The following is a description of a gene set: Human Gene Set: GSE19923_E2A_KO_VS_E2A_AND_HEB_KO_DP_THYMOCYTE_DN We wanted to test the role of mammalian E proteins E2A and HEB in the development of T cells. Using a conditional deletion system in which these proteins are deleted at the DP stage of T cell development, we compared DP thymocytes deficient for E2A, HEB or both to wild-type thymocytes Genes down-regulated in double positve thymocyte: TCF3 knockout versus TCF3 and TCF12 knockout. from publication D'Cruz LM, Knell J, Fujimoto JK, Goldrath AW (PMID 20154672) studied in species Homo sapiens, and this is the list of marker genes: UTP3, CRTAP, RASA1, LAP3, SURF2, EIF2B2, FMC1, IDI1, RPL22L1, MYH3, HACD3, EMP1, NCF4, RMDN3, SEMA4D, ANXA5, GK, LGALS3, PLA2G12A, IL13, FHL2, TRAF1, POU2F2 (NCBI Gene Id 5452), ISG15, NUP35, EHF, CR2, GARS1, AIMP2, WNT1, ECE1, NUPR1 (nuclear protein 1, transcriptional regulator), IL10, NUCB2, RCN1, MAPK6, GEM, PSMA6, DAP, TMEM11, TPD52, DDX18, PPDPF, DNAJC1, GGH, IFIT1B, PMS2, NFKBIA, GZMB, CAPN2 (calpain 2), IL4, CD53, CCL7, PTN, LIAS, UBE3A, SERPINB9, CNDP2, SLC1A5, HSD17B12, FDPS, NSUN2, SPP1, NFU1, DNAJB9, CTSB, CASP6, STXBP1, TXNIP, CSTF2T, TM7SF3, GSN, ANXA2, GCH1, AREG, SLFN12L, NID2, PPA2, PLXND1, RUFY1, SRGN, EGR2, ENPP1, NCKAP1, BTG1, AK1, MRPS24, BOP1, ZFYVE16, TBRG1, PLOD3, XCL1 (NCBI Gene Id 92337), CDK8, INSRR, CAPG, CTSC, UGCG, PDZK1IP1, ELL, SUN1, PTPN6, LDLR, ZNF282, MX1, DUSP6, SCEL, MTIF2, FRRS1, ITGAV, TMCO1, SLC12A7, NXF1, ALDOA, SEPTIN9, METAP2, ANXA1, PNPT1, PRKCE, CD82, FBXL5 (NCBI Gene Id 26234), IRF7, JUNB, IL6, SMS, TXNRD2, TANK, DUSP19, ASIP, MRFAP1L1, SLC4A7, FAAP20, KLRG1, NUDCD2, ESF1, UBC, IL5, IFNB1, COX7A2, PTP4A2, ELL2, BCL2A1, RRS1, CSNK1E, CCL1, DNAAF10, CDK5, FURIN, GADD45B, RGS10, EPS15, SLC44A1, NUS1, HASPIN, TWF1, RAD51B, LRBA, CCL5, ACP3, HDDC2, CAPRIN2, ALCAM, GADD45A, PRPF19, RAD52, UTP4, NUDT9, ACSL4, FPGS, ANKRD40, LAT2, EIF3D, MYC (MYC proto-oncogene, bHLH transcription factor), NOP2, ACP5, TSPAN5, ECH1, SRSF11, C3AR1, CCL4 (C-C motif chemokine ligand 4), CSN3, HIBADH, TTC7B, LAG3, SLC52A2, CD52, DLD, CD8B, TMEM268, GNG12, IL15, GPD2 (glycerol-3-phosphate dehydrogenase 2), LAS1L, APBB1IP, FXYD5, RSAD2, ITGAX, MR1, PTH, SH2D2A, KCNAB2